Given this list of marker genes Apoa5, Acsl5, Pla2g3, Kat2b, Nr1h2, Sirt2, Hnf4a, Nr1h3, Rgn, Cd74, Gdf15, Klhl25, Avpr1a, Mapk9, Cpt1a, Apoc2l, Dgat1, Abcd2, Slc45a3, Ppargc1a, Adipoq, Ghsr, Lpgat1, Twist1, Nucb2, Abcd1, Irs2, Pparg, C1qtnf2, Srebf1, Il1b, Plin5, Akt2, Anxa1, Mid1ip1, Irs1, Apoc2, Mlxipl, Obp2a, Ppara, Pla2g4a, Agt, Fabp1, Apoa4, Mlycd, Ppard, Avp (arginine vasopressin), Ptgs2 (NCBI Gene Id 19225), Elovl5, Mtln, here is a description of the gene set: Any process that activates or increases the frequency, rate or extent of the chemical reactions and pathways involving fatty acids. studied in species Mus musculus Mouse Gene Set: GOBP_POSITIVE_REGULATION_OF_FATTY_ACID_METABOLIC_PROCESS